The following is a description of a gene set: Human Gene Set: MIR599 from publication Chen Y, Wang X (PMID 31504780) studied in species Homo sapiens Genes predicted to be targets of miRBase v22 microRNA hsa-miR-599 in miRDB v6.0 with MirTarget v4 prediction scores > 80 (high confidence targets)., and this is the list of marker genes: JAM2 (NCBI Gene Id 58494), TBL1XR1, ILDR2, FAM111B, TNRC6B (NCBI Gene Id 23112), MTHFD2L, SOX9, CHD7, ANKRD13B, NRXN1, SART1, KLHL29, PLEKHM3, STAT1, NLGN3, BPNT2, C5orf24, NFIA, XG, KIAA0040, DNAJC24, MYOZ2, SLC10A7, UVRAG, MAF, CDK8, QSOX1, ERBB3, CHCHD10, PGR, PDE1C, CEACAM21, EDIL3, COX15, ANHX (anomalous homeobox), CERS2, SLC30A10, PLCB4, RFX1, ZFP30, ADAM12, LSAMP, PMP2, SORCS1, PDE4D, TCF12, ATMIN, ROCK1, MAB21L2, TFAP2A, DLG2, HPCAL4, CFAP44, CNOT9, NRDE2, NSL1, TAF2, TSC22D1, ZNF134, GPD2, ZSWIM6, SNX29, RAG2, PGGT1B, TGFB2, PDE3A, ACVR2B, CYP26B1, BST1, CNTNAP2, BIRC6, LRRFIP2, IL1RL1, LMCD1, LRRC8C, TSHZ1, CARD16 (NCBI Gene Id 114769), IGF1, CARTPT, MPC2, SLC2A12, PRKD1, LRRC4C (NCBI Gene Id 57689), MAPK10, CEP135, C2orf88